Given this list of marker genes Cspg4, Sdc4, Hs6st1, Hpse (heparanase), Agrn, Sdc2, Gpc4, B4galt7, Ext1, Ndst2, Ndst4, Idua, Glb1l, Gpc5, Gpc3, Glb1l2, Ndst3 (NCBI Gene Id 83398), Gpc6 (NCBI Gene Id 77735), Gusb, B3gat2, Bgn, Hs3st1, Bcan, Gpc2, Ids, Hs3st6, Naglu, Dcn, Sdc3, B3gat1, Xylt2, B3galt6, B3gat3, Glb1l3 (galactosidase, beta 1 like 3), Cspg5, Hs3st5, Ext2, Gpc1, Slc35d2, Sdc1, Hs3st4, Uxs1, Hs6st3, Hgsnat, Hpse2, Hs2st1, Ndst1, Glb1, Sgsh, Hs3st3a1, Vcan, Hs3st2, Xylt1, Hs6st2, Hs3st3b1, here is a description of the gene set: Heparan sulfate/heparin (HS-GAG) metabolism Mouse Gene Set: REACTOME_HEPARAN_SULFATE_HEPARIN_HS_GAG_METABOLISM species: Mus musculus